The following is a description of a gene set: MAPK signaling Human Gene Set: WP_MAPK_SIGNALING studied in species Homo sapiens, and this is the list of marker genes: MAPK8IP1, CRKL, MAP3K7, PPP3R2, NRAS, PRKACB, CASP3, FGF2, FGF21, DUSP9 (dual specificity phosphatase 9), RAF1, STK4, GNG12, JUN, FLNC (NCBI Gene Id 2318), STK3, FLNB, FGF11, TNFRSF1A, NFATC3, NTRK1, CACNA1B, LRRK2 (NCBI Gene Id 399472), TAB2, KRAS, MEF2C, NFKB1, CACNA1C, MAPK14, MAPK1, MAPK9 (NCBI Gene Id 5601), CDC42, FGF17, RELB, MAP2K1, ELK4, MAP3K5, RPS6KA5, PDGFB, GRB2, FGF4, DUSP7, RAC3, TGFBR2, CACNA1S, PTPN5, MAPT, RASGRP2, TGFB1, CACNA1I, CACNA1E (NCBI Gene Id 777), MAP3K14, FGF18 (NCBI Gene Id 8817), ATF2, CACNA1D, IKBKB, MAPK8, MKNK1, FGF3 (NCBI Gene Id 2248), MAP3K11, IL1R2, MAP3K4, ARRB1, MAP2K6, PLA2G4A, HSPA8, CACNA2D3, MAP4K3, NLK, DUSP4, CACNA1F, TRAF2, LAMTOR3, PTPRR, CACNA1G, PDGFA, FGF23, FGF19, TNF, PLA2G4C, ATF4, RAP1B, MAP4K1, RAPGEF2, RRAS2, FGF16, EGF, CACNB1, FGF9, MAPK10, MAP3K6, MYC, PPM1A, MAPK8IP2, MAP3K8, PRKCD, NTF3, PRKCA, FGF10, RASGRP1, EGFR, AKT3, SOS1, DUSP8, CACNA2D1, NR4A1, ECSIT, AKT2, STMN1, TGFB2, CACNA2D4, SOS2, FAS, FGFR2, MAX, PLA2G4E, CACNB3, IKBKG, BDNF, ELK1 (NCBI Gene Id 2002), IL1B, FGFR3, AKT1 (AKT serine/threonine kinase 1), MAP3K20, CD14, DUSP16, PLA2G4B, PLA2G4D, FGF14, HSPA6, DDIT3, MAPK13, FGF1, HSPB1, NFKB2, MAP2K3 (NCBI Gene Id 92079), RASGRF2, MAP3K12, RAC2, HRAS, MAP3K1, HSPA1B (heat shock protein family A (Hsp70) member 1B), MAPK11, DAXX, MAP2K2, PPP5C, CACNA1A, PRKACA, PPP3R1, HSPA1A, MRAS, FASLG, MAPK8IP3, MAP2K4, PPM1B, TRAF6, ARRB2, NF1, DUSP10, CACNG6, RRAS, MAP2K5, JUND, TGFB3, PLA2G4F, RPS6KA4, CRK, HSPA1L, CACNG7, CACNB2, MAP3K2, PAK2, FGF7 (fibroblast growth factor 7), TAOK2, SRF, IL1A, MAP2K7, PRKACG, FGFR4, MAP4K2, RAP1A, DUSP1 (NCBI Gene Id 1843), FGF8, PPP3CB, FGF20, TAOK1, FGF5, NFATC1, NGF, PAK1, GNA12, PPP3CA, GADD45A, CACNG5, RASA2, MKNK2, HSPA2, CACNA1H, DUSP3, MAP4K4, CACNB4, IL1R1, FGFR1, RAC1, MAPKAPK2, ARAF, NTRK2, DUSP6, TAOK3, DUSP2, RPS6KA3, RASGRP4, RELA, FLNA, MAP3K13, CACNG1, CHUK, TAB1, MAPK12, FGF6 (fibroblast growth factor 6), CACNG8, FGF22, MAPKAPK3, SMIM40, RASA1, PTPN7, PDGFRB, CACNG3 (NCBI Gene Id 10368), CACNG2, CDC25B, RASGRF1, FGF13, PPP3CC, RASGRP3, CACNA2D2 (NCBI Gene Id 9254), MAPK7, CACNG4, FOS, MAPKAPK5, TGFBR1, BRAF, MAPK3 (mitogen-activated protein kinase 3), PRKCG, FGF12, NTF4, TP53